Given this list of marker genes MAPK1, DUSP3, DUSP4, DUSP7, PPP2R1A, PPP2R5D, PPP2CA, DUSP6, MAPK7, PPP2CB, MAPK3, VRK3, PPP2R1B, here is a description of the gene set: Human Gene Set: REACTOME_ERKS_ARE_INACTIVATED studied in species Homo sapiens ERKs are inactivated